The following is a description of a gene set: Mouse Gene Set: GOBP_RHOMBOMERE_DEVELOPMENT studied in species Mus musculus The process whose specific outcome is the progression of the rhombomere over time, from its formation to the mature structure. Rhombomeres are transverse segments of the developing rhombencephalon. Rhombomeres are lineage restricted, express different genes from one another, and adopt different developmental fates., and this is the list of marker genes: Mafb, Gbx2, Hoxa2, Hoxa1, Pax6, Egr2, Hoxb3, Hoxb1 (homeobox B1), Hoxb2